Given this list of marker genes FAM43A, SLC22A23, FAM167A, MYO1D, MYCT1, KCNT2, DPPA3, MAP4K3-DT, CLDN11, TLR4, SLC25A23, CDKN2A, EXOC6B, ANKRD1, NLRP1, ATXN1, OTULINL, CD200, NRXN3, NALF1, LINC01694, ITGA2, INKA2, GCKR, AREG, ABCA6, IL1B, ANGPTL4, DMD, MARCHF4, PLAT, PDGFRL, TNFSF4 (TNF superfamily member 4), DPP4, SAMSN1, SNX25, PSPH, MAFF, VEPH1, PANTR1, TFPI, CLCN4, CSGALNACT1, RGS4, ZNF582-DT, RNF145, CREM, TRAV8-3, COL13A1, RHOJ, C15orf48, ITIH4, SERPINB2, SLC7A5, RGS7BP, ALDH1A3, ADAM23, PDE10A, LMO2, SEPTIN9, LINC02615, PCDH10-DT, KCTD16, C2CD4A, RBMS3-AS3, SERPINE1, SCG2, PTPRR, GATA6, LZTS3, AADAC, PTGIS, ADAMTS12, USP53, GLRX, SLC24A3, HGD, EIF4EBP1, GDF15, here is a description of the gene set: Genes up-regulated in multiple myeloma (MM) bone marrow mesenchymal stem cells. studied in species Homo sapiens from publication Corre J, Mahtouk K, Attal M, Gadelorge M, Huynh A, Fleury-Cappellesso S, Danho C, Laharrague P, Klein B, Rème T, Bourin P (PMID 17344918) Recent literature suggested that cells of the microenvironment of tumors could be abnormal as well. To address this hypothesis in multiple myeloma (MM), we studied bone marrow mesenchymal stem cells (BMMSCs), the only long-lived cells of the bone marrow microenvironment, by gene expression profiling and phenotypic and functional studies in three groups of individuals: patients with MM, patients with monoclonal gamopathy of undefined significance (MGUS) and healthy age-matched subjects. Gene expression profile independently classified the BMMSCs of these individuals in a normal and in an MM group. MGUS BMMSCs were interspersed between these two groups. Among the 145 distinct genes differentially expressed in MM and normal BMMSCs, 46% may account for a tumor-microenvironment cross-talk. Known soluble factors implicated in MM pathophysiologic features (i.e. IL (interleukin)-6, DKK1) were revealed and new ones were found which are involved in angiogenesis, osteogenic differentiation or tumor growth. In particular, GDF15 was found to induce dose-dependent growth of MOLP-6, a stromal cell-dependent myeloma cell line. Functionally, MM BMMSCs induced an overgrowth of MOLP-6, and their capacity to differentiate into an osteoblastic lineage was impaired. Thus, MM BMMSCs are abnormal and could create a very efficient niche to support the survival and proliferation of the myeloma cells. Human Gene Set: CORRE_MULTIPLE_MYELOMA_UP